Given this list of marker genes B4GALNT1, PRKAA1, PIGV, PIGH, ST3GAL4, ST3GAL2 (NCBI Gene Id 729518), PIGU, B3GALT1, PIGW, GAL3ST2, ST3GAL5, PGAP4, ST6GALNAC3, PIGX, B3GALT2, UGT8, ST8SIA6, FUT9, FA2H, SLC30A5, B4GALT4 (NCBI Gene Id 8702), PIGO, GAL3ST3, PGAP2, GBGT1, PIGA (phosphatidylinositol glycan anchor biosynthesis class A), FUT2, ST8SIA1, CERK, B3GNT5, ST6GALNAC4, GAL3ST4, B4GALT5, A4GALT, ST8SIA2, ST6GALNAC6, DPM2 (dolichyl-phosphate mannosyltransferase subunit 2, regulatory), DPM3, PIGZ, A3GALT2, PIGT, PIGC, B3GALNT1, ST3GAL1, PIGF, C20orf173, PGAP1, ST3GAL6, B4GALT6, PIGN, PIGB, SCCPDH, ST6GALNAC5, B3GALT4, GPAA1, PIGP, FUT1, ST3GAL3, PIGG, CWH43, PIGL, PGAP3, GAL3ST1, MPPE1, B4GALT3, TM9SF2, FUT4, PIGK, DPM1, PIGY, ST8SIA4, FUT6, ST8SIA5, ST8SIA3, PIGM, UGCG, PIGS, LARGE1, PIGQ (NCBI Gene Id 9091), here is a description of the gene set: The chemical reactions and pathways resulting in the formation of glycolipid, a class of 1,2-di-O-acylglycerols joined at oxygen 3 by a glycosidic linkage to a carbohydrate part (usually a mono-, di- or tri-saccharide). Human Gene Set: GOBP_GLYCOLIPID_BIOSYNTHETIC_PROCESS studied in species Homo sapiens